The following is a description of a gene set: from publication Amit I, Garber M, Chevrier N, Leite AP, Donner Y, Eisenhaure T, Guttman M, Grenier JK, Li W, Zuk O, Schubert LA, Birditt B, Shay T, Goren A, Zhang X, Smith Z, Deering R, McDonald RC, Cabili M, Bernstein BE, Rinn JL, Meissner A, Root DE, Hacohen N, Regev A (PMID 19729616) mouse primary BMDCs were stimulated with tlr ligands and gene expression changes were profiled on Affymetrix arrays Human Gene Set: GSE17721_LPS_VS_CPG_4H_BMDC_DN species: Homo sapiens Genes down-regulated in comparison of dendritic cells (DC) stimulated with LPS (TLR4 agonist) at 4 h versus DC cells stimulated with CpG DNA (TLR9 agonist) at 4 h., and this is the list of marker genes: QNG1, CTBP2, XPOT, SREBF2, SPATA13, EVI5, ZNF287, SQOR, MSRB1, NINJ1, MRPL41, TYSND1, TSR1, AOC1, RALBP1, THUMPD3, PEA15, GMNN, S100A11, NAGK, GLB1L, TEX261, CDCA5, MRAS, PLGRKT, SARS1, IGF2BP3, ACO1, FKBP15, ASH2L, LAMTOR2, TRPM7, AARS1, PDPK1, NSMCE4A, LPGAT1, EIF1AX (eukaryotic translation initiation factor 1A X-linked), YPEL3, PTCD2, RFC1, DNAJB6, C14orf119, SH3BGRL3, PLEKHO1, PEF1, TOMM40, TAX1BP3, PHF5A, MICOS10, PIK3C2A, NUDCD2, ADAM17, NOP2, C3orf70, ZNF22, UXT, OMA1, RIBC1, IPP, EIF3I, LCORL, NDUFB10, INTS6L, TTLL1, TAF10, GNPTAB, IARS1, PBDC1, EGLN3, P2RX6, COQ9, DDX10, THUMPD1, PPM1D, LSS, CBR1, PEBP1, PPP1R14B, GDI2 (NCBI Gene Id 2665), LSM10, SHOX2, GCDH, NSDHL, SMC6, SRSF6, MPV17, PARP2, ADH5, PTPRR, GMFB, UTP11, ALOX12B, SQLE, PAG1, DNAJA3, NSMF, TMED3, PDF, KLHL7, RAB31, SACM1L, AP2A2, TNFRSF8, STRBP, TMEM176B, SEC11A, BRAT1, CHMP1A, CERS2, MAGIX, HINT1, STK19, STRN, SLC5A6, SPINT1, TCF12, SLC25A19, RAP1A, CHRDL2, GNAS-AS1, TMED7, HEPH, RNASE4, TWF2, ARSI, CLCA1 (chloride channel accessory 1), DTYMK, TP63, TMEM51, PCBD2 (pterin-4 alpha-carbinolamine dehydratase 2), MRPL11, LSM1, ATG5, HSCB, NFE2L3, FOXN2, NSFL1C (NSFL1 cofactor), APOBEC1, CERK, CDC34, TSPAN14, DDX18, CCDC65, DUSP26, KIF16B, MCFD2, AIFM1, CCDC47, DHX57, SRSF9, EMC7, PGRMC2, MYADM (NCBI Gene Id 91663), NOP16, TJP2, FBXO8, FAM50A, CDK2AP1, SUPT20H, ATOSB, KPNA2, DHX8, MPDU1, FZR1, CCDC117, CCDC115, ATP5PB, POLR2D, REG1A, DNAJC18, GMFG, ZDHHC6, TRIAP1, SLC30A3, LAS1L, RNASEK, ADAM8, EIF5, ZSCAN26, SMARCAL1, LACTB2, ACP2, MICOS13, POLA2, SPIC, IRF2BP1, SHISA2, MTRES1, PRRG2, CEP20, SVIL, CHMP5, CSTB, HNRNPA2B1, CMAS, UQCC2, SRXN1, DDIT3